Given this list of marker genes CPLX1 (complexin 1), ARHGAP44, RAB11A, GRIPAP1 (GRIP1 associated protein 1), VPS35, STX3, GRIP1, GRIP2, SLC1A1, SCRIB, RAB8A, VAMP4, SACM1L, CLSTN1, LRRC7, NSG1, here is a description of the gene set: Human Gene Set: GOBP_NEUROTRANSMITTER_RECEPTOR_TRANSPORT_TO_PLASMA_MEMBRANE The directed movement of neurotransmitter receptor to the plasma membrane in transport vesicles. studied in species Homo sapiens